Given this list of marker genes Acadvl, Dbi (diazepam binding inhibitor), Dbil5, Acbd3, Scp2, Hadha, Acbd6, Soat1, Pnpla3, Acadm, Acbd5, Eci2, Hnf4a, Acadl, Hspa8, Gcdh, Hmgcl, Acot7, Soat2, Acbd7, Pitpna, Eci3 (enoyl-Coenzyme A delta isomerase 3), Acads, here is a description of the gene set: Mouse Gene Set: GOMF_FATTY_ACID_DERIVATIVE_BINDING studied in species Mus musculus Binding to fatty acid derivative.